Given this list of marker genes Casq1, Camk2d, Ccl3, Ccr5 (NCBI Gene Id 235693), Mettl21c, Hrc, Nol3, Chd7, Cacna1c, Calm2, Gstm7, Ank2, Calm1, Gsto1, Pln (phospholamban), Tmem38a, Dmd, Itpr1, Ryr1, Fkbp1b, Fasl, Calm3, Ryr2, Pde4d, Casq2, Trdn, Slc8a1, Tmem38b, Dhrs7c, Ryr3 (NCBI Gene Id 99099), here is a description of the gene set: The directed movement of calcium ion from endoplasmic reticulum to cytosol. studied in species Mus musculus Mouse Gene Set: GOBP_RELEASE_OF_SEQUESTERED_CALCIUM_ION_INTO_CYTOSOL_BY_ENDOPLASMIC_RETICULUM